The following is a description of a gene set: studied in species Homo sapiens Human Gene Set: HP_ABNORMAL_EMOTIONAL_STATE Abnormal emotional state Emotions are complex psychological states that involve three distinct components: a subjective experience, a physiological response, and a behavioral or expressive response. In an abnormal emotional state, an affected individual shows altered intensity, frequency, or duration of emotional experiences., and this is the list of marker genes: IFNG, TSPOAP1, SLC16A2, ABCC6, GCH1, RNASEH2B, SLC6A19, STAT4 (NCBI Gene Id 6775), NTRK1, MYO7A, GIGYF2, MT-TL1, MAOA, BANK1, NAXD (NCBI Gene Id 95526), SLC26A9, NEXMIF, SATB2, SMO, SNCAIP, SLC46A1, NPHP1 (NCBI Gene Id 4867), NOTCH3, PER3, ATP1A2, HTR2A, IRF4, ESPN, VAPB, PERCC1, RNF168 (ring finger protein 168), ADAR, HLA-DQB1, ACOX1, RNASEH2C, SPG11, MT-CO1, GABRB3, SEPSECS, MSTO1, TNIP1, ADA2, MT-TQ, SDHD (NCBI Gene Id 91899), ALPL, BMPR1A, NDP, GPR35, PDGFB, MSH6, PFN1, HMOX1, MT-TL2, TP53, DRD2, SYNGAP1, DLL1, DAO, IL12A, MED23, SLC39A4, GBA1, XPR1, IFIH1, CHCHD2, FGFR1, FBP1, AIP, MATR3, ERBB4, UBA5, TMEM237, ATRX, PXK, NUP160 (nucleoporin 160), SLC25A4, P2RY11, GCDH, LRRK2, NF2, DISP1, VPS53, CR2, ASL, TRIM32, MAPK1, IL10, ADNP, ATP13A2, UBAC2, TNFSF4, CHEK2, GLDC, AVP, TBX1, ATM, PMS2, NUP205, EDNRA, TRANK1, DCTN1, ASH1L, CABP4, MT-CO3, PPP2R5D, EP300, MMP1, BBS9, SPART, RNF13, DGUOK, PON3, MIR17HG, CLCNKA, JAZF1, POGZ (NCBI Gene Id 23126), PTH, SLC1A3, OCRL, VDR, UBQLN2, SIX3, FOXH1, OPHN1, BBS7 (Bardet-Biedl syndrome 7), BLK, IGHG1, UFC1, MED12, MAMLD1, GLA, KISS1R, QDPR, SERPINA1 (NCBI Gene Id 5265), ANG, WT1, ARV1 (ARV1 homolog, fatty acid homeostasis modulator), PDE11A, CLCA4, BBS1, TLR7, SLC7A6OS, DAAM2, GNB2, LIMK1, SNCA, SEMA4D, CEP85L, MT-ND1, CREBBP, FIG4, OSTM1, PLA2G6, CASR, MSH2, ST3GAL3, TRHR, PROKR2, TET3, BBS5, B4GALNT1, DNAJC5 (DnaJ heat shock protein family (Hsp40) member C5), HMBS, PIK3CA, DNM1, FGF17, EIF2B1, TRPC6, ALDH7A1, TBL2, CSF1R, EFHC1, SPAST, HSPG2, UCHL1, ARL6 (ADP ribosylation factor like GTPase 6), MTPAP, TWNK, AMPD2 (adenosine monophosphate deaminase 2), MAN2B1, FBP2, IFT74, SPTBN1, GCLC, PANK2, AP2S1, MAGI2, GRIN2A, SMC1A (NCBI Gene Id 8243), SOD1, YIF1B, COASY, GCSH, OTC, CNTNAP2, CRKL, PTRHD1, SLC2A3, NDUFS1, SARDH, MLH1, FGF14, CDH23, PGK1, MAPT, CD2AP, SEC24C (SEC24 homolog C, COPII coat complex component), HS6ST1, PYCR2, GYS2, HTRA2, EIF4H, NFIX, LMO1, TH, SCLT1, LIN28B, ADH1C, DNAJC6, WARS2, EPCAM, PYGL, SMARCA2 (NCBI Gene Id 95083), BBS4, NRCAM, CEP290, ARVCF, TSEN15, IFNGR1, AQP2, MPV17, NCF1, GTF2I, BAP1, COMT, RNU4-2, DNMT1, NHLRC1 (NHL repeat containing E3 ubiquitin protein ligase 1), CLIP2 (NCBI Gene Id 84805), SLC11A1, FKBP6, BBS12, ATXN3, IL12A-AS1, SDHAF1, TCF4 (transcription factor 4), ASNS, ATP9A, ARHGDIA, NPHS2, PRF1 (NCBI Gene Id 5551), EHMT1, RPS6KA3 (ribosomal protein S6 kinase A3), ALDH4A1, MYO1E, UFD1, USH2A, BBS2, MOCS2, TUBB3, CLCN4, CTSH, STX1A, PDCD6IP, NUP133, DCTN4, TRAF7, GLE1, ATP7B, PINK1, SMARCB1, SLC6A17, TREX1, SLC1A2, CYP27A1 (cytochrome P450 family 27 subfamily A member 1), VPS13A, WFS1, CRB2, DPAGT1, NODAL, SDCCAG8, CACNA1I, KCNT1, CLCNKB, TARDBP, PON2, GLI2, ALAD, CEP19, DARS1, SGCE, AVPR2, FMO3, MECP2, CRIPTO, COL4A3, ASS1, MT-CO2, NUP93, LAS1L, PAX2, TACR3, UBE2L3, KMT2A, PHGDH, MUTYH, ARMC5, KCNJ2, MT-TW, TERT, HTRA1, STIL (STIL centriolar assembly protein), DNAJC13, AKT1, SCAPER, GRIK2 (glutamate ionotropic receptor kainate type subunit 2), POLD1, ATXN10, SLC1A4, ITGAM, OPTN (NCBI Gene Id 337928), ADGRV1, WHRN, ALK, NDUFA2, CLP1 (NCBI Gene Id 10978), VPS35, MT-TH, HNRNPA1, GNAS, ATXN2, TGFBR2, TK2, ETS1, EIF4G1, MAPK8IP3, SMPD1, WDPCP, SLC6A4, ERAP1, RELN, ASPA, GNRH1, UQCRC1, CLRN1, ABCA7, CEP78, TTC8, DPYD, CIB2, PMS1, NDUFAF4, CRH, IFT27, ASAH1, C19orf12, FOXRED1, ABCC8, POLG2, SYNJ1, CTSF, ZNRF3, ABCB11, SEMA4A, ENPP1 (NCBI Gene Id 5167), BSND, FMR1, SRPX2, MEN1, DNA2, MT-TF, NUP37, SLC39A14, SLC25A1, GABRG2 (gamma-aminobutyric acid type A receptor subunit gamma2), SLC20A2, SAMHD1, GRN, RREB1, FUS, COG4, CHRNB2, TPH2, CDKN2B, GP1BB, ACTN4, ANXA11, P4HA2, ITPR1, PARK7, CYP2R1, NAA60, WDR11, NHLH2, COQ2, DNAJC30, EXOSC8, GLRX5, HLCS, ENSG00000288330, KISS1, CFAP410, IMPDH2, CNP, TSHB, HIKESHI, GNA11, CFAP418, PPP2R2B, ARSA, RFX7, ATP1A3, GDAP2, SDHB, PCBD1, GAPVD1, BPTF, CISD2, CHRNA2, ZNF365, POLR1A, MIF, C4A, TTI2, VCP, CLTRN, GALC, JRK, CYP27B1 (NCBI Gene Id 5135), FDFT1, PER2, HIBCH, SLC25A19, MYCN, ELN, MT-TS2, KIAA0319L, ZFX, VPS37D, CARS1, KCNN4, SCARB2, FTL, SLC25A20, CAMK2B, NPHS1, BCS1L, SUCLA2 (NCBI Gene Id 8803, succinate-CoA ligase ADP-forming subunit beta), CPOX, ATP5F1A, FXN, GTF2IRD1, NSMF, TREM2, CLN8, VPS13C, PTPA, ABCB7, ABCB4, CHD2, CAMK2A, STAG2, NUP85, GRIA4, PRKCG, SNORD118, AIFM1, CDKN1A, CHCHD10, PUF60, C9orf72, HLA-B, AFG3L2, VPS50, PSAP, GAS1 (NCBI Gene Id 2619), HTT, PCDH15, TGIF1, IL23R, NAXE, TSC1, MST1 (macrophage stimulating 1), TBC1D7, HFE, ARSG, TBC1D8B, CHMP2B, PTS, MEFV, GSN, CACNA1G, TMEM106B, CBS, PODXL, BCR, PHOX2B, CDON (cell adhesion associated, oncogene regulated), BBIP1, CCNF, USP48 (NCBI Gene Id 84845), AMACR, COQ8B, KDM5C (lysine demethylase 5C), TYROBP, RFC2, PDZD7, PDCD1, NEFH, ST3GAL5, CACNA1H, PI4K2A, CFTR, STX16, HLA-DQA1, USH1C, TMEM270, CHRNA4, PPT1, KLRC4, DCX, FCGR2B, HCRT, HLA-DRB1 (major histocompatibility complex, class II, DR beta 1), SLC2A1, PTPN22, TTC19, TLR4, ZFYVE26, HDAC8, NR1H4, PRNP, ITPA, ZIC2, DEPDC5, PSEN1, PROK2, GPR101, PRKAR1A, CHD8, CUX2, FA2H, SPR, SMARCE1, HBB, NAA10, METTL27, RNASEH2A, FOCAD, LSM11, GNRHR, DGCR6, TAC3, ATXN8OS, SPP1 (secreted phosphoprotein 1), AARS2, UNC13A, RNU7-1, EMP2, NACC1, GABRA1, FOXG1, TRMU, MAPK10, APOL1, FGF8, TOR1A, RNF125, TNFAIP3, RRM2B (NCBI Gene Id 50484), CEACAM3, HIRA, TNIK, PLCH1, SLC9A3, ESS2, CLN6, CCR1, GLT8D1, POLE, FKBP5, NR4A2, TGFB1, INF2, MT-ND4, DDC, PRKACA, ALG9, CACNA1A, ANKFY1, CUL4B, AP2M1, DGCR2, SLC6A1, EPM2A, PON1, CDKN2A (NCBI Gene Id 1029), GTF2IRD2, LEPR, ATP8B1, MT-ATP6, GATAD2B (GATA zinc finger domain containing 2B), IRF5, KRAS, NEK1, DEAF1, MT-ND5, PLCE1, CDKN2C, SUFU, IRAK1, DUSP6, THOC2, JMJD1C, KCTD17, SHH, TBP, STUB1, AR, PTPRO, CTNNB1, BUD23, IFT172, HACE1 (HECT domain and ankyrin repeat containing E3 ubiquitin protein ligase 1), IDUA, ATP2A2, ANLN, LGI1, IBA57, PDGFRB, SLC6A3, CPS1, PSMD12, TRMT5, NDUFA6, GSTM3, TSC2, TDO2, TBK1, MKS1, CEACAM6, BRCA2, PTCH1, GPRC5B, FCGR3B, C4B, AP1G1, RPS20, SLC25A13, ELP1, NAA20, CHD7, XK, CTLA4, NUP107, TAF15, SLC19A3, NAGS, BBS10, MT-TN, DGCR8, PRRT2, KMT2B, SCN1A, MT-TT (mitochondrially encoded tRNA-Thr (ACN)), TCN2, GALT, BAZ1B, PLP1, ARHGAP24, SLC6A14, SQSTM1 (sequestosome 1), MT-ND6, KDM1A, SRPK3, SDHA, MOG, NR3C1, LZTFL1, COL7A1, PPARGC1A, CTCF, CDKN1B, FLT4, PRPH, HARS1 (NCBI Gene Id 3035), NSDHL, AOPEP, PAH, PRKN, PLPBP, BRAF (B-Raf proto-oncogene, serine/threonine kinase), ARG1, USH1G, NHLRC2, MTHFS, MKKS, USP8, DNASE1, JPH3, EXOC8, SPRY4, POLG, FAS